Given this list of marker genes TTK, AURKC, PSMA8, SMPD3, SLC25A31, BUB3, ABRAXAS2, NDC1 (NDC1 transmembrane nucleoporin), CKS2, L3MBTL1, ZCWPW1, ANAPC11, ANKLE2, MEIKIN, PIN1, MFF, ZSCAN21, MSH5, CDCA8, HSPA1B, PDGFRB, TPX2, SPATA22, MSX1, RAD54L, MAPT, AURKB, EPGN, CDC20, H2BW1, LCMT1, NFIB, NDEL1, PEX11A, PDE3A, NDE1, SMC1A, RAD21, CCSAP, FMN2, TERF1, ACTR3, MYBL1, PSMG2, CCNB1IP1, DCAF13, MARF1, AKAP8L, SKA2, INSR, MOS, CCDC61, NEK2, TRIM75, SPC24, CHMP7, KNTC1, BECN1, MTFR2, FOXJ3, DMC1, NSMCE2, WASHC5, BRDT, CENPI, KIF2C, RANGRF, MARCHF5, BMP4, BRIP1, RAD50, PRKN, PEX11G, XRCC3, PINK1, LSM14A, SYCP3, SEC16B, TRIP13, WNT5A, VPS4B, NCAPG, KATNB1, UBE2B, GEN1, ACOX1, ZWINT, CEP97, CHEK1, NIPBL, DDB1, CDK5RAP2, WAPL, KIF25, TOP2B, NCAPH2, DDHD1, EDN3, CHMP3, KIF18A, MEI4, MAP10, RACGAP1, SHCBP1L, DRG1, UCP2, C9orf78, AURKA, APC, CHMP2A, CHMP4C, KIF4A, SLX4, PINX1, DMRTC2, CALR, DMRT1 (doublesex and mab-3 related transcription factor 1), SKA1, NPM2, MAD2L2, MIS12 (NCBI Gene Id 79003), PDGFB, CHMP1B, NUMA1, TEX12, RIPOR2, PPP1R9B, NSFL1C, KNL1, KCTD19 (NCBI Gene Id 146212), GDAP1, RAD51AP1, C1orf146, TUBG2, WNT4, CD28, PGAM5, NCAPD2, NDC80, RAD51D, SIRT2 (sirtuin 2), CHMP4BP1, SMC3, MTFR1, VPS4A, TEX19, SYCE1, TUBG1 (tubulin gamma 1), CENPF, MRE11, GOLGA2, DCTN2 (dynactin subunit 2), EML4, TEX11, KASH5, NCAPD3, CTDP1, LRP5, RAB24, PSRC1, MASTL, CEP55, MND1, PEX19, PTEN, EME2 (essential meiotic structure-specific endonuclease subunit 2), TEX14, TGFA, HASPIN, KAT5, C11orf65, ANAPC7, CHEK2, SPAST, FBXW5, PRP4K, CENPC, HSF5 (NCBI Gene Id 124535), ING2, SYCE1L, SPO11, OPA1, PDXP, FBXO5 (NCBI Gene Id 26271), NUSAP1, MAD2L1, CHFR, DIS3L2, SHOC1, OFD1, CLASP2, EDN1, BTC, BUB1B, KLHDC8B (kelch domain containing 8B), FGF8, GPR3, RAN, IRGM, KIF11 (kinesin family member 11), REC8, MAPRE1, IL1B, RAD51B, SPIRE1, USP16, FANCA, UHRF1, RANBP1, KAT2B, ESPL1 (NCBI Gene Id 9700), NME6, CDC14A, STRA8, CENPK, CHMP5, NUP62 (nucleoporin 62), CDC16, CDK1, KLHDC3 (NCBI Gene Id 116138), MAP9, TPR, MCMDC2, HSF1, COX10, NUF2, MEI1 (meiotic double-stranded break formation protein 1), TEX15, RHOA (NCBI Gene Id 387), DDHD2, TOM1L1, SPDL1, EGF, RALBP1, RALA, CENPX, TMCC1, NFE2L1, FBXO43, MYBL2, MLH3, SMC2, SMARCA5, MAPK15, MTFP1, NFIA, CDCA2, CCNE1, DCN, SPC25, POLDIP2 (DNA polymerase delta interacting protein 2), PEX11B, IGF1, RAD1, UBE2S, INF2, HOXA13, MLH1, CNTD1, SEPTIN1, NCAPG2, AKAP8, RAD51C, SIRT7, RBM46, BAG6, KMT5A, ASPM, FIGNL1, TDRD9, MYO19, TOP2A, CAV2, CLASP1, PSMC3IP, KIF18B, TOM1L2, BCL2L11 (BCL2 like 11), REEP4, STAT2, BANF1, ANKRD31, OBSL1, RMI1, SPDYA, MAD1L1, CHMP4A, CCDC8, CDC42, CUL3, DRD3, AP3B1, ORC4, SEH1L, CCNB2, RGCC (regulator of cell cycle), ANLN, TTN, ABRAXAS1, BOD1, FANCD2, UBB, INS, SPAG5, SLC25A46, CDKN1B, PRICKLE1, PIBF1, TAF1L, RAD51, PTTG1 (NCBI Gene Id 9232), MSH4, HORMAD1, ANKRD53, MIEF2, TDRKH, STAG2, DNM1L (dynamin 1 like), KNSTRN, ZNF207, CDC14C, RPS6KA2 (NCBI Gene Id 6196), OOEP, DUSP1, AAAS, CEP85, KIF23, RAD54B, AURKAIP1, BORA, ASZ1, CYRIB, NPR2, MAJIN, UBR2, BNIP3, EHMT2, KDR, EPS8, KIF22, RPL24, RPL10L, MAEL (maelstrom spermatogenic transposon silencer), HSPA2, DDX4 (DEAD-box helicase 4), TOP6BL, PRMT5, PHIP (NCBI Gene Id 83843), STAG1, PPP2R2D, ANAPC5, CDC25C, IL1A, ZW10 (zw10 kinetochore protein), CYP26B1, MAD2L1BP, SYCP1, RAB11A, PLCB1, BCCIP, ANKLE1, SYCP2, LIF, FZR1, TUBB8, MTFR1L, PLK1, UBE2C, HNRNPU, RCC1, ERCC4, TDRD12, BAZ1B, MUL1, KPNB1, CHAMP1, NUDC, RNF212B, KIF15, CCNA1, EML3, AGO4, TNF, CDT1, KIF20B, MIURF, MEIOB, CUL7, NSL1, ATM, PRC1, UBXN2B, BTBD18, PTTG2, MOV10L1, PPP2R1A, CENPS, CDCA5, NANOS2, MEIOSIN, CATSPERZ, ACOT8, USP44, SLC2A8, PSMD13, TENT4A, PIWIL2, IK, SIRT1, SH2B1, C14orf39, PRDM9, NCAPH, CUL9, P3H4, ANAPC15, SMC4, RMDN1, BUB1, KIFC1 (NCBI Gene Id 95229), ZWILCH, HSPA1A, BIRC5, CHMP6, CCNB1, SYCE2, TERB1, ZNF541, NEUROG1, MTCH2, HFM1, MZT1, CHMP2B, MTBP, TGFB1 (NCBI Gene Id 7040), EME1, IHO1, UBE2I, WRAP73, BRME1, RNF212, IGF2, MISP, CHMP4B, PRAP1, KLHL22, BRCA2, HSF2BP, ARHGEF10, DAZL, CDC25B, DLGAP5, CENPE, MEIOC, CORO1C, MKI67, SPHK1, MROH1, FLNA, SPIRE2, DYNC1LI1, CCDC66, MUS81, CDC23, KIF14, CCNE2, CHMP1A, CRYZL2P-SEC16B, RRS1, TERB2, FANCM, PDCD6IP, PPP1CC, SKA3, TMEM135 (transmembrane protein 135), KIF3B, SGO1, INCENP, RB1, CEP192, REEP3, PTTG3P, ACTR2 (NCBI Gene Id 10097), PKMYT1, SYCE3, FIS1, KIF2A, DAPK3, MCU, SUN1, MSX2, SPICE1, EREG, FOXJ2, DNMT3L, PPARG (NCBI Gene Id 5468), VPS35, PHF13, MIEF1, BROX, BMP7, INO80, LRRK2, STAG3, TESMIN, WEE2, CDC14B (cell division cycle 14B), KIF4B, CDKN1C, M1AP, here is a description of the gene set: The creation of two or more organelles by division of one organelle. species: Homo sapiens Human Gene Set: GOBP_ORGANELLE_FISSION